The following is a description of a gene set: Human Gene Set: MODULE_525 Genes in the cancer module 525. species: Homo sapiens, and this is the list of marker genes: TAGAP, C1orf159, INSIG1, RAB8B, INTS7, TRAK1, CD164, NUP205, MMEL1, AGO2, KLRA1P, DNAJC5B, LBR (lamin B receptor), FYTTD1, BET1L, NOC3L, THOC7, AEN, FMNL1, MESD, P2RY8, MT1G, NMD3, KBTBD8, PMAIP1, WSB1, ULK4, SLC8A2, G3BP2, NOX4 (NADPH oxidase 4), HLA-DRB3, WDR75, EAF1 (ELL associated factor 1), ANKRD44, C2CD5, STARD4, PKD1, TAF1D, NFKBID, APOA2, SYNE2 (spectrin repeat containing nuclear envelope protein 2), EXOC6B, MFSD14B, ARL8B, SGCD, IRS2, TLE4, FEM1A, ORAI2, DHX15, STK10, DIABLO, PTPN11, ZMIZ2, LBH, PELI1, CD69, PPTC7, LIPA, MIOS, DDX49, SNRNP200, DBF4, NSUN2, ANKRD20A1, KLHL15